Given this list of marker genes CDC37, BAX, UGT1A6, EP300, IFNG, MGST1, HES1, TGFB1, AHR, IL17B, EGFR, SLC7A5, UGT1A7, CAP2, UGT1A1, CYP1A2, SRC, UGT1A4, IL12B, AHRR, PTGES3, NFE2L2, IL1B, ARNT (NCBI Gene Id 405), ALDH3A1, IL2, SERPINB2, POLK, CYP1B1, JUND, AIP, UGT1A9, CES3, IL12A, TNF (tumor necrosis factor), IGFBP1, HSP90AA1, NCOA1, JUN, NQO1, MYOF, JUNB, GSTA2, CYP1A1, CDKN1B (NCBI Gene Id 1027), here is a description of the gene set: species: Homo sapiens Aryl hydrocarbon receptor pathway Human Gene Set: WP_ARYL_HYDROCARBON_RECEPTOR_PATHWAY_WP2873